The following is a description of a gene set: Mouse Gene Set: GOBP_NEGATIVE_REGULATION_OF_NEUROTRANSMITTER_SECRETION Any process that stops, prevents, or reduces the frequency, rate or extent of the regulated release of a neurotransmitter. species: Mus musculus, and this is the list of marker genes: Pnkd, Slc30a1, Nf1, Syt4, Prkn, Htr6 (5-hydroxytryptamine (serotonin) receptor 6), Ggcx, Asic1, Ppp1r9a